The following is a description of a gene set: Human Gene Set: HP_RETINOSCHISIS Splitting of the neuroretinal layers of the retina. studied in species Homo sapiens Retinoschisis, and this is the list of marker genes: NR2E3, RS1, OAT, CLCN2, ACTG1, GFPT1, MFRP, ACTB